The following is a description of a gene set: Unlocalized atrophy of the brain with decreased total brain matter volume and increased ventricular size. studied in species Homo sapiens Global brain atrophy Human Gene Set: HP_GLOBAL_BRAIN_ATROPHY, and this is the list of marker genes: CHCHD10, ASL, PLA2G6, CAD, PNPO (NCBI Gene Id 55163), CYP27A1, SQSTM1, PCDH19, PANK2, ASNS, PUF60, SNF8, SCN2A, NAXE (NCBI Gene Id 128240), GNB1, AFG2A, RNU4-2, ERCC6, CYB5A, SUCLA2, FUS, CSF1R, AGTPBP1, ST3GAL5, AIMP1, DOHH, GABRG2, UNC80, TPK1, TIMM8A, TDP1, RAB3GAP2, VARS1, COPB1, VCP, CARS2, PYCR2, PSAP, ABCD1, TXN2, SATB1, WARS2, RNF113A, SCN1A, PIGT, SON, SCN1B, GFM1, OTUD5, LYRM7, ALG9, GABRA1, DPAGT1, CYB5R3, TBCK, WDR81, SNCA, PLP1 (proteolipid protein 1), CNPY3, ALG13, TANGO2, CYLD, FBXL4, DHCR7, TARDBP, ACTL6B, L2HGDH, TBK1, SCN9A, SMG9, NUP214, PRNP, ARX